Given this list of marker genes FIGNL2, CLPB, VPS4A, IQCA1, HSPA1B, NSF, KATNAL2, NOTUM, IQCA1L (IQ motif containing with AAA domain 1 like), HSPA1A, KATNA1, KATNAL1, HSPA8, SPAST, FIGNL1, FIGN, here is a description of the gene set: species: Homo sapiens A molecular function that involves direct binding to one of the subunits of a protein-containing complex and promoting the dissociation of one or many subunits. This often happens by changing the conformation of the protein being bound, which decreases its affinity for the rest of the complex. Human Gene Set: GOMF_PROTEIN_CONTAINING_COMPLEX_DESTABILIZING_ACTIVITY